The following is a description of a gene set: species: Homo sapiens Human Gene Set: GSE16451_IMMATURE_VS_MATURE_NEURON_CELL_LINE_WEST_EQUINE_ENC_VIRUS_DN from publication Peltier DC, Simms A, Farmer JR, Miller DJ (PMID 20483728) Genes down-regulated in neuron cell line infected with western equine encephalitis virus: immature versus mature cells. Human neuronal differentiation alters responsiveness to innate immune stimuli and virus infections. We used microarrays to examine the transcriptional responses of the human BE(2)-C neuroblastoma cell line to infection with western equine encephalitis virus (WEEV)., and this is the list of marker genes: SUCNR1, UBE2G2, SEC11C, ATP1B1, NETO2, IL3, QTRT1, C1orf216, EYA3, THOP1, PHGDH, NRAS, PWP2, ITFG1, ALKBH2, POLR2D, LMNB2, TFAM, TRUB2, SELENOI, SERPINH1, HSPBP1, EIF2B2, CHCHD4, ARMCX5, DDX56, DHFR, SMC2, MRPS18A, SRM (spermidine synthase), DDX54, MED8, DUSP6, HIRIP3, SSRP1, TOMM22, MTX1, ENTPD1-AS1, CYREN, PGM2, DNAJA4, OTUD4, TMEM39A, WARS1, NANP, METTL8, PLAGL2, FSD1, CCDC86, HNRNPH3, TACO1, SLC39A3, MFSD2A (NCBI Gene Id 84879), THUMPD2, POLR3H (RNA polymerase III subunit H), TXLNA, WDR73, LYAR, PEMT, BLTP2, CD226, NFKBIA, CENPM, BCS1L, RAB27A, RBM19, PITPNA, TNF, POFUT1, HSPA2, ZBTB32, SND1, C19orf48P, TRIB1, NAA10, YBX3, LRP8, FUT8, RXYLT1, CCDC137, MRRF, MAPKAP1, CDK5, CHAC1, MTIF2, XPR1 (NCBI Gene Id 9213), TNFRSF4, ARPC1A, VPS25, POLR3B, HOMER1, HIVEP3, ORC1, SLC16A1, GPT2, IMPDH1, SLC25A39, URB2 (URB2 ribosome biogenesis homolog), FANCE, LAS1L, VWA8, CREB3L2, PSMA3, ALG5, GPAA1, ZNRD2, ADNP2, SNX4, RBM8A, TSPAN5, RNF14, DTL, AEBP1, TPK1 (NCBI Gene Id 27010), TOMM40, TNFRSF18, FAM136A, RMDN3, GINS2, SFXN4, LBHD1, SPINT2, CD109, MAGOHB, TEDC2, MAPKAPK3, DDX18, PDIA6, TLCD1, GMFB, SLC11A2, OIP5, RAE1, RRS1, CAMTA2, SLAMF1, CEP15, GFPT1, SMARCAD1, MTAP, ORMDL2, MRPL1 (mitochondrial ribosomal protein L1), DPH6 (NCBI Gene Id 89978), MRPS14, COASY, ALDH18A1, WDR12 (NCBI Gene Id 55759), LPP (NCBI Gene Id 4026), ACAD9, PDGFA, NUS1, TRAP1, PUDP, TBX21, ZNF239, IPO4, REL, LAG3, CCT5, BRF2, TBRG4, CDK6, CCNB1, DNAJA3, MFN2, SLC25A19, PCCB, TRIP13, THOC1, ESPL1, IMPACT, NSUN2, CSTF3 (cleavage stimulation factor subunit 3), PTPN7, POLR1C, TIMM10, PTRH2, SUV39H2 (NCBI Gene Id 79723), CISD3, ARV1, PIGM, CENPS, TMEM33, GTF3C6, PFAS, PYROXD1, CLPB, PIGW, EXOSC4, CLIC4, CISD1, LIG3, SLC1A5, EGR1, PPP1R10, PCBD1 (NCBI Gene Id 5092), CLN6, ATOX1